Given this list of marker genes Csnk1e, Plk1, Atg7, Cdc20b, Mapk8, Rnf180, Csnk1a1, Bbs7, Socs4, Gclc, Hspa1a, Chfr, Hamp, Dda1, Plk3, Fbxw8, Zfand2a, Nop53, Sh3rf1, Zer1, Fbxo22, Plk2, Dnajb2, Trf, Psmd10, Psen2, Trib2, Il33, Sumo2, Nub1, Nkd2, Stub1, Zyg11b (zyg-ll family member B, cell cycle regulator), Axin1, Sirt2, Dvl1, Gabarap, Sirt6, Rchy1, Gsk3a, Mdm2, Cdc20, Socs5, Aurka, Det1, E330034G19Rik, Trib1, Vcp, Cbfa2t3, Prickle1, Klhl40, Csnk1d, Rad23a, Sirt1, Ddrgk1, Hspbp1, Ube2v2, Sh3rf3, Lrrk2, Usp5, Akt1, Clu, Mapk9, Pias1, Fzr1, Hspa1b (NCBI Gene Id 15511), Dab2, Psen1, Pabir1, Gba1, Cop1 (COP1, E3 ubiquitin ligase), Prkn, Rbx1-ps, Rack1, Rbx1, Paqr3, Sumo1, Gsk3b, Sh3rf2, Bag2 (BCL2-associated athanogene 2), Trib3, Axin2, here is a description of the gene set: Any process that activates or increases the frequency, rate or extent of the breakdown of a protein or peptide by hydrolysis of its peptide bonds, initiated by the covalent attachment of ubiquitin, and mediated by the proteasome. studied in species Mus musculus Mouse Gene Set: GOBP_POSITIVE_REGULATION_OF_PROTEASOMAL_UBIQUITIN_DEPENDENT_PROTEIN_CATABOLIC_PROCESS